Given this list of marker genes LSM8, MT-TH, CSNK1G1, ELOVL7, KLHL7 (kelch like family member 7), LOXL3, TAF3, TNPO1, FAM47E, PCCA-DT, MIA2, BNIP2, DENND4A, GFI1, FAF2, STING1, EGLN2, KIAA0319L, MT-ND6, RPL22L1, GCSH, MIR3190, HLA-C, IFT70A, LUC7L2, ANKRD36B, AP3S2, PDE12, MBD2, PDLIM1, MIR1915HG, UBAC2-AS1, GNAT1, MCRIP2, IQUB, TSEN34, IER3IP1, ABHD17AP4, DNAJC19, MTHFD2L, PIK3R2, FOXD3-AS1, MT-TL2, CRISPLD2, RSRP1, ADAM1B (ADAM metallopeptidase domain 1B (pseudogene)), LGALS8-AS1, BAG6, CLUAP1, CTXND1, DLGAP1, TRAPPC6A, GNA11, MRNIP (NCBI Gene Id 51149), MIR9-1, CLIP3, FMC1-LUC7L2, MIR17HG, HOXB7, TRIM54, MMACHC, MIR320A, CALM1, DONSON, MT-TY, CCNA1, PTPRK, TMEFF2, NIPAL1, SOX2-OT, SFRP2, SNORD27, CHRD, MPP1, ATP6V0D1, BPHL, ZFAND2A, C6orf141, C14orf119, BORCS7-ASMT (NCBI Gene Id 100528007), IREB2, CNOT3, ZBTB37, PGLS, HIVEP3, B4GAT1, MTF2, UBE4A, TP53RK, ARGLU1, NRN1, CNOT1, SPAG17, ITGA3, PSMD14, TNNT1, SUB1, TANC2, HLF, TMEM232, HOXB3, GTF2H4 (general transcription factor IIH subunit 4), SAV1, CDK5RAP3, LINC02865, ARHGEF7-AS2, LINC02453, SNAP23, FOXC2 (forkhead box C2), RNU6-2, SLC37A4, ATXN7, EEF1B2, THA1P, FCF1, LGALS8 (NCBI Gene Id 3964), PAX7, MT-ND1, TRABD, RNF13, ARL14EP, FAM98B, PER1, BMPR1B, CFAP410, TOMM40L, SMARCC2, C1orf74, SNCA, VARS2, RNF19B, BAZ1B, SLC2A3, GSK3B, NR2F1, LHX1, BTBD6, PEX1, GTF2F2, NSA2P1, BEND3, ZNF114, IGFBP6, ZNF213, NEUROG2, EFHD1, CHKB-CPT1B, SC5D, FOXG1, TRAPPC14, BRF1, CLN8, CDK8, NAT16, CSE1L-DT, GFPT2, PDGFRL, GNB5, MAP1LC3A, UBE2Q1, PCDH10, TRPC6, STIMATE, STAM2, POT1, CHURC1-FNTB, CAB39, ERG, ATE1OSP, TFAP2A, INTS12, UTP3, PIP4K2C, ZNF114-AS1, SUCLG1, RN7SKP241, SNORD48, CREB5, EMX1, LINC01596, NAA35, MRPS18A, SLC15A4, EIF2AK3, TRIP11, KIF9, DACH1, NECAP1, EEF1AKMT2, RBFOX2 (RNA binding fox-1 homolog 2), GNAO1-DT, MIR9-2HG, ZNF213-AS1, SEPTIN7P14, PHF11, IDH3B, PDE4C, HSCB, SNHG1, WDR91, NXF1, STON2, CHURC1 (NCBI Gene Id 91612), MBOAT7, MEGF8, FAM161B, ITPR2, HOXB-AS4, GAR1, PARP10, SHISA5, PTPRZ1, PRPF8, RHOF, BCL11B (BCL11 transcription factor B), C9orf85, MSH5, RTF1, KLHL18, CDC42EP5, SF3B6, BMP3, LINC01569, ZFYVE28, WRAP73, PREX2, METTL2B, FMC1, TEX2, SOX2, MAPK8IP3, FBXL18, TMEM178A, ABCC3, RNU6-551P, CITED1, TXNRD1, ATP6V1A, HDAC9, COX7A2, SUGCT, IGSF9B, INO80B-WBP1, XPOTP1, NSUN4, MAPK3 (NCBI Gene Id 5595), INO80B, TUBA3GP, EFEMP2, MT-TS2, CNTD1, LGI3, SSBP3P1, SNHG3, MT-TN, PHOX2B, CSGALNACT1, LYST, ELAVL1, LINC01391, ATG12, PLP1, CCDC90B, CHD4, GNAO1, GSDMD, BARHL1, FMO4, BNIP3L, SEC23IP, ZNF439, PLPP6, GOSR2-DT, ZNF385D, PLXNA4, GPAM, CHORDC1 (cysteine and histidine rich domain containing 1), SLN, EFEMP1, WIF1 (WNT inhibitory factor 1), BDH1, LINC01133, BORCS7, AJUBA, MTND4P24, ARMC10, GRAMD1A, PRPF40B, SLC25A35, RPL35AP2, ARMH1, PKIA, TRIOBP, IGF2BP1, UBL7-DT, IFI6, ABHD12, KLHL7-DT, CFAP20, TAL1, FEZF1-AS1, SUZ12P1, DCP1A, COX10-DT, HAR1B, GPN3, MIR1915, CYP2R1, MYH11, POLH, AJUBA-DT, OBI1, ZNF585B, LINC02541, LINC01972, FAM47E-STBD1, RESF1, GTF2IP12, SP2-AS1, CDK12, CCL26, EFNA3, MTTP, KCTD10, NAA50, PAX5, NIT1, BZW1, MT-ND4, GRHL2, LHX1-DT, EDEM2, SNORA24B, PABPC4, ENSG00000236543, VKORC1, ANKHD1-DT, DCLRE1B, ZNF570, CPB2-AS1, YIPF6, HDAC5, EXOC4, SNORD25, RAB29, RNU6-563P, NKX2-4, CFLAR-AS1, EXPH5, ZNF805, CIMAP3, NFIB-AS1, MTCO3P12, WEE2-AS1, TBC1D19, LINC00662, GBA1, ZBTB24, MDM4, UBE2HP1, COPS5, HSPBAP1, MTF1 (NCBI Gene Id 4520), SKI, MAPRE1, NUP42, PHETA1, PRELID3B, COA3, NKX6-1, MECOM, MIR9-1HG, NR1H2, ZNRF2P3, ZNF598, CXCL2, CHEK2, FGF10-AS1, ZNF701, GPR85, AKAP3, DSTYK, KRR1, CALM3, SLC16A10, CASP3, MAST4, SGMS1, HACD3, ZNHIT2, TFG, RPGRIP1L, DAXX, TENT4A, ZNF140, TESHL, RCC1, APOM, SLC22A20P, PAQR3, ATG4A, SPINT2, WT1-AS, GDNF-AS1, RAB8A, ABCC10, TLCD2, MIR4311, GAS5, HOTAIR (HOX transcript antisense RNA), SULF2, RAD51B, ENSG00000283573, HOXB8, UFC1, PCCA, IQGAP2, HPGD, ZDBF2, MT-TA, MINDY3, LEF1-AS1, GOSR2, RPS6, RBCK1, PCYT1A, HDAC2-AS2, NDUFB10, VGLL2, TTLL1 (NCBI Gene Id 25809), HCG14, PAPLN, GABRB2, FAM107B (family with sequence similarity 107 member B), PPP1R9A, DPP9, UBE2Z, SREK1, OTX1, APEX1, SYPL2, ATXN7L3B, POU2F2, CYP27A1, SH2D6, GMCL1, GABRA6, ACTR5, LYN, MT-TE, RABL3, QRICH1, LRRC43, SLC7A2, RAB43, ZNF451, ORC3, RLIG1, SULT1B1, CREBBP, BTN2A3P, DOK1, RPL11, IGHMBP2, PDZD8, APPL2, CHKB, SHANK2, CIB1, CCDC9, CGN, SLC25A20, ELMOD2, HOXC12, ENSG00000287636 (novel transcript, antisense to C7orf33 and CNTNAP2), RAB27A, MRNIP-DT, ATXN7L1, MACF1, LHPP, NEK3, FAM87B, DLX2, DTNA, SLC25A3, FOXO3 (NCBI Gene Id 2309), ECH1 (NCBI Gene Id 1891), DNM3OS, PRR15, ADRA1A, ERI1, RBM17, SYT1, SEPTIN11, COPG2, LINC01607, LPIN3, EN1, PRKCZ-AS1, GPRASP3, XPO5, AKAP17A, TBR1, TEX30, M6PR, TAF1, IGFBP5, ATP5F1A, ZNF843, PSORS1C1, C6orf62, GAR1-DT, DNAJC22, POLR2B (NCBI Gene Id 7890), PIAS4, IFTAP, UBE2V1, MSTO1, DAB2, CHRNE, SLC25A46, KIAA2012, TMED9, SKOR2, GAS7, RINT1, MTND5P11, DGKI, RHBDL3, HMGB1P37, CTIF, AFAP1, MIR199A2, ARID1A, BMP4, ERCC4, FRMD4A, MPLKIP, ROBO3, PHF14, CYP26B1, MOB3A, CECR7, COMMD2, C8orf34-AS1, C1QTNF1, PTMS, NGDN, PSME3IP1, TLX2, BMERB1, C19orf47, NUMA1, PAFAH1B2, OSGEP, CDKN2A, URGCP, KCTD9, LNC-LBCS, GRINA, DPEP1, LSG1, MT-TL1, RARS2, MMP19, SNX31, SPSB3, STK3, IGF2BP3, MCM2, RNA5SP240, RPS15, KLHL8, LIN28B, RMRP, SPATS2, C8orf76, PCAT6, SLFN13, POLG, PFKFB2, UBE3B, MICU1, PCDH10-DT, CBX2, ASNSD1, TPD52, STIMATE-MUSTN1, CSNK1G3, PPIAP47, ZNF490, DMRTA2, SLC44A2, COL19A1, ADGRV1, BAG3 (BAG cochaperone 3), PSIP1, P2RX2, MT-CYB, C6orf132, ZC3H13, TMEM150C, PRR15-DT, RNU2-37P, TLK2, ITGB5, NDUFA9, NMNAT1, ATP6V0A1, CDK1, PRKCI, RNY3P4, RUBCN, CLIP1, AP3S1, UNC5CL, NME1, CENPBD2P, FUS (FUS RNA binding protein), TPR, MX1, ENDOG, ARMH3, SIRT1, AP2S1, CACNA1C, MXI1, FOXP1-AS1, CFAP99, LMTK2, FOXCUT, DEPDC1B, PANK3, ADAMTSL4, IFT140, FBXO15, HAR1A, MAIP1, CFL1, RPL7AP60, WDR59, MED11, NCAPD2, SNORD123 (small nucleolar RNA, C/D box 123), MAPK10, MT-TR, CAMK2B, PIMREG, GPI, ACIN1, DRAIC, NME1-NME2, EVX2, FAM228B, EIF2AK3-DT, PPP1R13L, RPUSD3, ZNF350, FOXA1, ANGPTL4, TRAPPC4 (trafficking protein particle complex subunit 4), COL25A1-DT, OLIG3, ARHGAP27, LRCH3, COG3, RPL26L1, PAX6, MED14OS, NR5A2, MYO9B (NCBI Gene Id 4650), RPL28, LMAN2, PHLDB1, LHX6, YOD1, ZNF554, CHPT1, ZNHIT3, IL17D, SNHG32, GATA3, MAST2, NUBP2, RAET1L, BAMBI, ATP6V1C1, GRAMD1A-AS1, TRBV13, RLF (NCBI Gene Id 6018), SPRY1, CHP1, RIMOC1, RAD23A, RUVBL1, TBX20, SHMT1, PCDH19, SOWAHA, ZNF608, CD70, FOXI3, THNSL1, ENOSF1, TMEM170A, TXNIP, BLOC1S3, RABEP2, RPS4X, UBC, SOX3 (NCBI Gene Id 8256), MAZ, CCDC159, LBX1-AS1, SNRNP70, MT-TT, C9, RORB, NASP, SFPQ, ZCWPW1, EHBP1-AS1, TMEM259, SEPHS1P6, GNAS, CSPP1, MLEC, EBPL, TOMM40, MED20, AMPD3, ARIH2, GNAI2, RNU6-1073P, KLRG1, AP4B1 (NCBI Gene Id 10717), PITPNM3, MIR6068, STK11, THBS4, IGDCC4, NT5DC4, TLE2, MARK2, SEPHS2, IGSF10, SH2B1, ZIC2, KRT8, CENPU, GYS1, ZNF106 (NCBI Gene Id 64397), SATB2, ZNF682, ENKUR, RNVU1-3, FRG1HP, MLH3, CPT1C, CELF2, E2F6, CPAMD8, ANKRD19P, PIK3C3, UNC80, ANKHD1-EIF4EBP3, DISP1, RUNX3, CHD7, RPS4XP9, GATA3-AS1, HAUS1, KBTBD11-AS1, AIP (NCBI Gene Id 9049), COL25A1, LINC02447, NAA16 (NCBI Gene Id 79612), KIAA1191P2, ABHD12B, RNF220, PSMC4, UBXN1, MT-TC, POLR1G, H2AZ1-DT, DPYS (dihydropyrimidinase), HEY1, RAD51AP2, RPS25, PRP4K (pre-mRNA processing factor kinase PRP4K), COPZ2, AP3D1, NDST1, KLHL20, NKX2-6, ZBTB17, ABHD17B, B4GAT1-DT, RNF6, LIMD2, UGGT2, CCDC107, GATAD1, FAM135A, MEPCE, TMEM184B, SLC8A2, NHLRC2, ABCD3, ADPRS, MGAT4A, GPX8, HCG21, RFX2, SMCO1, ZNF786, ACTR3, TUBA1B, CHKB-DT, LINC01775, CDRT4, TNPO2, ZNF833P, LIN28B-AS1, SMYD4, CDC27, PNPO, ZBTB3, PSMD14-DT, DLX6-AS1, MAPK11, CAPG, MTMR4, NDUFS1, GMEB1, FGF1, TMTC1, CDHR3, CCNC, SENP5, NHLH2, COPS7A, SERTAD1, STAU2-AS1, SNORD26, SVIL, TRIM36, TGOLN2, RRP15, FAM216A, SLC12A4 (solute carrier family 12 member 4), POU4F1, BMPR1B-DT, PEX2, ZFAND2A-DT, DLX6, SLC15A1, MMP24, SUZ12, TYW5, FHL2, POLG-DT, STMND1, RORA-AS1 (RORA antisense RNA 1), CD55, TMEM176A, KCTD1, TRIO, RPL26L1-AS1, SSBP1, HOXA2, CCDC163, RUVBL1-AS1, B4GALT7, BCL2L1, CREB1, ZNF438, FITM2, C1QTNF6, TMEM115, SETMAR, TTC23, LINC02987, RAB11A, FOXG1-AS1, XPO4, ANKHD1, MT-ND4L, TPRA1, PRLR, EPHA3, TIMM21, NGFR, BMI1, ANXA11, PIGL, SFRP1, PSMA1, KANSL3, DYRK1A, TARID (TCF21 antisense RNA inducing promoter demethylation), MCOLN1, LINC01115, MB, INPP5B-AS1, LHX8, MIR5188, ZNF3, ZNF569, GLB1L3, DCLRE1A, WDR74, ERC1, SPAG7, MYOSLID-AS1, DLX1, TUBA1B-AS1, ATF3, MRPL51, ZIC4, SDC2, SEC16B, PDS5A, TMOD1, PAX9, BANP (NCBI Gene Id 54971), KIAA1586, LINC01143, PAAF1, EXTL3, LSM4, TAF5LP1, ALG14, MFAP3L, GCFC2, ENSG00000225280, NR2F1-AS1, LRRC8A, C14orf39, TRGV7 (T cell receptor gamma variable 7 (pseudogene)), ENTREP2, VMP1, SLC3A2, ITM2B, EXD1, BRSK2, U2AF2, LGI4, BBX, CLIC1, TMEM42, POM121 (NCBI Gene Id 9883), KYAT1, LRRC51, UBXN6, MBD1, FBRS, NCBP3, MX1-AS1, GSTCD, CCNI, INTS10, AREL1, IDH3B-DT, LINC01315, TNRC6B, GAS8, GSK3B-DT, VSNL1, H3-3B, TP53RK-DT, MIPOL1, TGFBI, ZRSR2, SOD1, here is a description of the gene set: Human Gene Set: CBX7_TARGET_GENES Genes containing one or more binding sites for (CBX7) in their promoter regions (TSS -1000,+100 bp) as identified by GTRD version 20.06 ChIP-seq harmonization. from publication Yevshin I, Sharipov R, Kolmykov S, Kondrakhin Y, Kolpakov F (PMID 30445619) studied in species Homo sapiens